Given this list of marker genes GRIA3, GJA1 (gap junction protein alpha 1), BRD4 (NCBI Gene Id 90616), KCNK9, VPS13B, PACS2, TBC1D24, COL11A1, CTCF, KCNMA1, BRF1, CACNA1I, ABCC9, PURA, FARS2, ATP6V1B2, here is a description of the gene set: Increased size of the incisor tooth. Human Gene Set: HP_INCISOR_MACRODONTIA Incisor macrodontia species: Homo sapiens